Given this list of marker genes Pfkp, Hk1, Eno1b, Pkm, Galk1, Bcl2l13, Pgam2, Src, Eno3, Hk2, Gapdh, Aldoa, Foxk1, Gpi1, Gale, Galt, Eno2, Pfkl, Pgk1, Pfkm, Foxk2, Eno1, Tpi1, here is a description of the gene set: The chemical reactions and pathways resulting in the breakdown of a carbohydrate into pyruvate, occurring through a glucose-6-phosphate intermediate, with the concomitant production of a small amount of ATP. Mouse Gene Set: GOBP_GLYCOLYTIC_PROCESS_THROUGH_GLUCOSE_6_PHOSPHATE species: Mus musculus